The following is a description of a gene set: Prostanoid ligand receptors Mouse Gene Set: REACTOME_PROSTANOID_LIGAND_RECEPTORS species: Mus musculus, and this is the list of marker genes: Ptgdr, Ptger2, Tbxa2r, Ptger3, Ptger1, Ptgdr2, Ptger4, Ptgir, Ptgfr